Given this list of marker genes RPL28, ZDHHC6, SELENOP, CLDN6, PRIMA1, GSTO1, OPN3, RALGDS, HPF1, DNAJC27, IMPA2, TF, DNAJB11, TAS1R1, NHP2, LXN, UNC5C, PUS7, PPP4C (protein phosphatase 4 catalytic subunit), RGS10, ADK, CD48, LYAR, RPL6, DUS3L, H2AX, CHURC1, STIL, ANXA3, INTS1, MTDH, PALD1, HSD3B2, SRP14, CENPT, POLR2B, AAAS, OMD, EEPD1 (endonuclease/exonuclease/phosphatase family domain containing 1), FABP7, MMP17, PRMT7, AKR1B1, ZC3H18, MYH1, TBRG4, STK10, SPRR2F, AVPI1, MRPL51, CCL13, BPGM, CETN2, DDX39B, CEACAM21, TOMM40L, PPP1R18, PTPN1, ANP32E, LHCGR, PFKP, RAP1A, FERRY3, LRRC59, DAPK1, DDR2, PEX19, MT2A, NUP85, CDK4, FMO1, PGF, S100A9, ITGA9, PARS2, GDAP1, ZIC4, PPIB, CGREF1, POLR2H, SASH3, CCT7, CDC20, FAM81A, IMP3, WNT7B, CD22, C19orf53, CCL1, RBM10, TNFAIP8, SMC3, CIITA, IPO4, OSTC, MRPS2, RRN3, SRSF9, MRPL28, GNMT, HAUS4, PHF5A, PABPC4, TRMT10A, KCNS2, EMC2, IRS1, CPZ, ALOX15B, ELOVL6, NKD1, TM4SF4, CEMIP, WDR12, MAFF, PCID2, GCG, TALDO1, COMT, PPIE, SAPCD1, DAG1, CD81 (CD81 molecule), MRPS24, RPS15A, SUZ12, SCRT1, RRP1B, HNRNPL, GDF15, TIMMDC1, SHMT1, HEBP1, TNFRSF18, QDPR, HPRT1, SESN1, LAMTOR4, ICOS (inducible T cell costimulator), GUSB, SERHL2, CLDN14, PHKG2, APOBEC2, CCNA2, NDUFB2, ANKH, FURIN, TDO2, ALDOA, AHCTF1, EBP, STMN4, NDRG2, HIP1, TMED9, SELENOV, POU6F1 (POU class 6 homeobox 1), CD164, GFM1, UXT, DNAJC3, NAA38 (N-alpha-acetyltransferase 38, NatC auxiliary subunit), NME2, MSLN, SLC7A5, ADSL, ABCF1, PPIC, MYBL2, MLYCD, EIF5A (eukaryotic translation initiation factor 5A), MOS, FGFR2, RPLP1, BTBD1, AKR7A2 (aldo-keto reductase family 7 member A2), RBBP7, NUP93, RP1, ALPG, SSR4, KIAA1143, MVK (NCBI Gene Id 4598), NUBP1, ACO2, LEPROT, MCM2, GAB3 (GRB2 associated binding protein 3), DNASE2B, CHST7, PITX1, PI4KA, PRKCD, CAPZA2, CDKN1A, MRPL48, KMO, here is a description of the gene set: mouse primary BMDCs were stimulated with tlr ligands and gene expression changes were profiled on Affymetrix arrays Human Gene Set: GSE17721_0.5H_VS_24H_POLYIC_BMDC_UP species: Homo sapiens from publication Amit I, Garber M, Chevrier N, Leite AP, Donner Y, Eisenhaure T, Guttman M, Grenier JK, Li W, Zuk O, Schubert LA, Birditt B, Shay T, Goren A, Zhang X, Smith Z, Deering R, McDonald RC, Cabili M, Bernstein BE, Rinn JL, Meissner A, Root DE, Hacohen N, Regev A (PMID 19729616) Genes up-regulated in comparison of dendritic cells (DC) stimulated with poly(I:C) (TLR3 agonist) at 0.5 h versus those stimulated at 24 h.